The following is a description of a gene set: The process in which a relatively unspecialized myeloid precursor cell acquires the specialized features of a mast cell. A mast cell is a cell that is found in almost all tissues containing numerous basophilic granules and capable of releasing large amounts of histamine and heparin upon activation. Human Gene Set: GOBP_MAST_CELL_DIFFERENTIATION species: Homo sapiens, and this is the list of marker genes: GATA3, STAT5A, KIT, ZFPM1, TAL1, PLA2G3, PIK3CD